The following is a description of a gene set: Mouse Gene Set: REACTOME_TRAFFICKING_AND_PROCESSING_OF_ENDOSOMAL_TLR Trafficking and processing of endosomal TLR studied in species Mus musculus, and this is the list of marker genes: Ctss, Unc93b1, Ctsl, Hsp90b1, Tlr9, Ctsb, Cnpy3 (canopy FGF signaling regulator 3), Lgmn, Tlr7, Ctsk, Tlr8, BC051665 (NCBI Gene Id 218275)